Given this list of marker genes PDGFRB, ALX4, SIX3, TONSL, PPP1R12A, USH1G, SLC25A24, here is a description of the gene set: Aplasia/Hypoplasia of the nasal bone species: Homo sapiens Human Gene Set: HP_APLASIA_HYPOPLASIA_OF_THE_NASAL_BONE Absence or underdevelopment of the nasal bone.